The following is a description of a gene set: Human Gene Set: REACTOME_DIGESTION_OF_DIETARY_CARBOHYDRATE Digestion of dietary carbohydrate studied in species Homo sapiens, and this is the list of marker genes: SI, AMY2A, AMY1A, CHIA, CHIT1, MGAM, TREH, AMY2B, AMY1B, AMY1C, LCT